The following is a description of a gene set: A subcompartment of the endoplasmic reticulum consisting of tubules having membranes with high curvature in cross-section. studied in species Homo sapiens Human Gene Set: GOCC_ENDOPLASMIC_RETICULUM_TUBULAR_NETWORK, and this is the list of marker genes: OSBPL8, PARP16 (NCBI Gene Id 54956), ASPH, REEP5, REEP3, ATL3, RETREG3, TMEM201, PARP8, RAB3GAP1, REEP1, ATL2, ZFYVE27, REEP4, LNPK, RTN4, EMD, RAB18, ARV1, ARL6IP1, REEP2, C2CD2L, KPNB1, ATL1, STIMATE, SPAST, RNF41, PARP6, STIM1, RAB10